Given this list of marker genes KCNJ5-AS1, NAA20, IGHA1, PIP4K2A, SERPINB6, CASP9, TMEM127, CIB1, GUSB, SNAI3, RAD51AP1, DCSTAMP, HIVEP2, TMED3, KLHL21, ME3, TTC39B, RHBDF2, MME, POR, SCCPDH, SLC45A3, PTGS1, BLVRB, DUSP10, SEL1L3, DNAJB11, GGN, GPR107, SIGLEC15, BCCIP (NCBI Gene Id 56647), ECH1, PHC1, CARD14, CD300LF, HSD17B14, MECR, ITGAE (NCBI Gene Id 3682), PLBD1, IL7R, EHF (ETS homologous factor), CABLES1, C2CD3, CALM3 (NCBI Gene Id 808), S100A8, RPS11, RAB42, DISP1, VLDLR, SAYSD1, FGF3, LMAN2L, FCGRT, GGA2, TMEM53, IFIT2, MRAS, SIPA1L2, KAZN, FLVCR2, IFIT3, ABHD5, PLCXD1 (phosphatidylinositol specific phospholipase C X domain containing 1), RUNX1, BLVRA, STX18, CD68, FERRY3, CTSD, PGBD5, TTC1, NANS, LPCAT3, TLR4, HSD11B1 (hydroxysteroid 11-beta dehydrogenase 1), COA3, TTC9, SNTB1, MORN2, TBL2, HPCAL1, APOC1, DENND5A, IFNAR2, AATBC, SARDH, FAM89A, TPD52L1, TSC22D1 (NCBI Gene Id 8848), PDIA4, CORO2A, IQGAP2, TXNDC12, GABARAPL1, STK38, TRMT12, FKBP15, KRTCAP3, DTX4, PEX14, DECR1, ADAM17, TMEM208, PC, PLIN2, PHLDA3, HNRNPA1L2, ABHD6, GPS2, STON2, EREG, PRKCE, HEXB, FHIT, EPAS1, BICRA, IK, NLRC4, APLP2, ATF3, ARIH2OS, FIRRM, LPXN, PTPRN2-AS1, PRAM1, DNAJC5B, EEPD1, AGAP11, MFSD11, NUP214, PLPP6, BST1, LAMP1, POLH, IL36B, WFS1, ITSN1, ENG, IDH1, KCNAB2, TBXAS1, CD52, PGS1, CD1D, ABCG2, S100A9, SAXO2, JAKMIP2 (janus kinase and microtubule interacting protein 2), LFNG, MYL4, MCEMP1, TGFB1, POLR2K, VNN2, CYBA, RAB20, NEU3, ERGIC3, SSR2, SPOCD1, CR1, CTSA, CD300A, TBC1D2, ATP11B, CD82, LBR, KCNE1, ACSL1, PNPLA3, NR1H3, NEU1, POLR3C, EIF4EBP2, RFPL2, OAS1 (2'-5'-oligoadenylate synthetase 1), FGR, C3, NXPE3, KPTN, TMEM230, WDR73, EAF2, SCARNA15, VWA5A, ITGA3, TRMO, LIMK2, LCMT2, GPCPD1, GPRIN3, PAPSS2, TMEM218 (NCBI Gene Id 219854), PRKCB, ITGAL, NHSL1, NDUFA2, here is a description of the gene set: studied in species Homo sapiens Human Gene Set: GSE44732_UNSTIM_VS_IL27_STIM_IMATURE_DC_DN IL-27 treated DCs were shown to be highly potent inhibitors of cis HIV-1, particularly of CCR5 tropic strains. Microarray studies of IL-27 treated DCs showed no up-regulation of Type I (IFN) gene expression. Neutralization of the Type-I IFN receptor had no impact on the HIV inhibition. Lastly, IL-27 mediated inhibition was shown to act post-viral entry and prior to completion of reverse transcription. These results show for the first time that IL-27 is a potent inhibitor of cis HIV-1 infection in DCs by a Type I IFN independent mechanism. from publication Chen Q, Swaminathan S, Yang D, Dai L, Sui H, Yang J, Hornung RL, Wang Y, Huang da W, Hu X, Lempicki RA, Imamichi T (PMID 23527130) Genes down-regulated in immature dendritic cells: untreated versus IL27.